Given this list of marker genes SLC25A21, UQCRFS1, RPL18AP16, MRPL44, OGDH, HSPA1L, MRPS30, FPGS, PDHA1, CPS1, ACOT9, ACAT1, GPT, CYBB, BID, CYC1, ALDH2, GDF15, HTATSF1, TIMM23, OAT, CYP11B2, MUTYH (NCBI Gene Id 4595), IDH3B, TSFM, FDX1, ACSL6, ABCB7, NDUFA5, COX11, FARS2, ABCF2, SLC25A14, TIMM13, PPIF, MTIF2, CYP27A1, GPX4, CYP11A1, WARS2, COX15, HSD3B1, FARSA, CLPX, ACADVL, GPD2, PDHX, COQ7, ACADM, GLUD1, NBN, NFS1 (NFS1 cysteine desulfurase), ABCB6, GOT2, UQCRC2, BCL2A1, NRF1, NDUFB5, MRPL16, MRPS16, BEX3, CYCS, NME4, TUFM, BCAT2, CYP27B1, CYB5B, FDXR, SLC1A3, MRPL12, ATP5MC3, GCAT, REXO2, TIMM8A, SHMT2, MLYCD, POLG2 (DNA polymerase gamma 2, accessory subunit), PPID, MRPL15, AZIN1, AGXT, HADH, HSPD1, SLC25A3, AKAP10, PDK4, MRPS14, DLAT, LYPLA2, MRPS15, CYP24A1, TIMM17A, SLC25A5, TXNRD2, MLH3, MRPL46, SDHB, BAD, IVNS1ABP, CASQ1, MRPL57, COX10, MTRF1, COX8A, HPS1, SCP2, COX6A2, TXN2, BCKDHB, PTPRA, HSD3B2, ACO2, PDK1, BLVRA (biliverdin reductase A), ACADSB, AKAP1, COX5A, PDP1, CRAT, IVD, MRPL35, MFN2, NDUFS1, SURF1, MPST, NDUFB3, NDUFA3, AIFM1, APAF1, TIMM10, CYB5R3, MRPS27, DGUOK, SLC25A28, H2BK1, TSPO (translocator protein), SLC25A37, FIBP, MRPL22, MRPS35, CLPP, MRPS18C, MRPL39, SUCLG1, GCK, OXCT1, CPT1B, MTCH1, TFAM, RPL3, RPS3A, NNT, AK4, DBT, CKMT1B, MRPS31, MRPL13, ATP5PF, PPOX, BDH1, VDAC2, GALR3, STAR, CYP11B1, GCFC2, DIABLO, MAST1, TK1, TBCB, UQCRB, MRPL42, ARG2, FH, MRPL19, ACSL4, BCL2, NDUFAB1, ACSL1, GOT1, SDS, IDH3G, GRID2, NPIPB3, AMT, GFM1, TK2, MRPL11, NR3C1, ATP7B, OTC, NDUFS2, ATP5PO, UQCRH, AFG3L2, NDUFC1, HMGCS2, ALDH18A1, PCK2, IDH3A, MRPL33, HAX1, NDUFS4, MTCH2, TOMM40, MRPS22, AMACR (NCBI Gene Id 23600), MMUT, SPG7, MRPL48, SDHA, GLYAT, CPOX, SLC25A40, ATP5F1B, TFB1M, ACAA2, COX7A1, ATP5MC1, NDUFA4, NDUFA2, NDUFS6, ATP5PB, ETFB, SLC1A1 (solute carrier family 1 member 1), NDUFB6, MRPL17, NPIPA1, IMMT, CASP8, SSBP1 (NCBI Gene Id 6742), ECHS1, MIPEP, MRPS17, CYBA (cytochrome b-245 alpha chain, NCBI Gene Id 1535), FXN, CPT2, NDUFS8, POLRMT, MCCC1, EMC8, BAK1, TOMM22, SHMT1, MRPL34, CA5B, HLCS, CS, CA5A, OPA1, ECI1, NDUFA7, ATP5F1D, PRDX3, GSR, MRPL18, FHP2, CYB5A, UQCRC1, SMCP, TST, GLS, ACSL3, HSPA9, TIMM8B, ATP5PD, STARD3, ATP5MC2, CLN3, MRPS18B, COX7B, ME2, LONP1, SLC25A4, POLG, NDUFS5, R3HCC1L, SUPV3L1, CRY1, ETFDH, NCAPH2, OXA1L, SDHC, UCP3, SLC25A15, MFN1, MRPS18A, MDH2 (malate dehydrogenase 2), NDUFA6, COX4I1, MTOR, HSPA1A, SUCLA2, ACADS, SLC9A6, BCS1L, DLST, ATP5MG, MRPL20, BCKDK, DAP3, MBD3, COX6A1, MRPS28, MTHFD1, MRPS34, NDUFC2, TAT, MAOA, ATP5F1E, MRPS2, ABAT, BCKDHA, SARDH, TIMM44, CNOT7, CPT1A, PIN4, SBNO2, IDH2, SOD2, ACSL5, MRPL9 (mitochondrial ribosomal protein L9), HK1, GATM (NCBI Gene Id 65211), PCCB, OGG1, HSPE1, NDUFV2, LARS2, DHODH, BNIP3, NDUFB2, DECR1, VDAC3, ATP5ME (ATP synthase membrane subunit e), CKMT2, HMGCL, MAOB, ABCB8, COX7A2, NDUFB4, COX7C, NDUFB1, PDHB, SLF2, MRPS12, ATP5F1C, OAZ3, ATP5IF1, ALDH4A1, NDUFA1, COX17, UROS, COX5B, PMPCB, SLC25A11 (NCBI Gene Id 8402), FECH, MRPL2, GLS2, MRPS7, ACAD8, NDUFA9, TOMM34, TIMM17B, MRPL4, ALAS1, HADHB, RAF1, ACP6, SDHD, HCCS, SLC25A13, SLC25A10, TRAP1, MTHFD2, TOMM20, DNASE2, ATP5MF, TXN, BCL2L11, ZNF33B, UQCR11, AK2, NDUFS3, TIMM9, ODC1, SLC25A20, ME3, MRPS33, ACADL, CDC37P1, NDUFB8, GAL3ST1, MPO, BNIP3L, DUT, PC (pyruvate carboxylase), HADHA, DLD, NDUFS7 (NCBI Gene Id 4727), BAX, GATB, RPLP2, SLC25A17, GCDH, COX6C, SLC25A1, COX7A2L, PDK3, MRPL24, LMF2, ENDOG, MRPS11, TOMM70 (NCBI Gene Id 9868), MRPS10, DNM1L, COX6B1 (NCBI Gene Id 1340), ETFA, DMAC2L, NDUFA8, PCCA, UCP1, MRPL49, TIMM22, BCL2L1, SLC25A12, NDUFB7, CBARP, UCP2, PYCR1, HCLS1, NDUFA10, here is a description of the gene set: from publication Mootha VK, Lindgren CM, Eriksson KF, Subramanian A, Sihag S, Lehar J, Puigserver P, Carlsson E, Ridderstråle M, Laurila E, Houstis N, Daly MJ, Patterson N, Mesirov JP, Golub TR, Tamayo P, Spiegelman B, Lander ES, Hirschhorn JN, Altshuler D, Groop LC (PMID 12808457) Human Gene Set: MOOTHA_HUMAN_MITODB_6_2002 DNA microarrays can be used to identify gene expression changes characteristic of human disease. This is challenging, however, when relevant differences are subtle at the level of individual genes. We introduce an analytical strategy, Gene Set Enrichment Analysis, designed to detect modest but coordinate changes in the expression of groups of functionally related genes. Using this approach, we identify a set of genes involved in oxidative phosphorylation whose expression is coordinately decreased in human diabetic muscle. Expression of these genes is high at sites of insulin-mediated glucose disposal, activated by PGC-1alpha and correlated with total-body aerobic capacity. Our results associate this gene set with clinically important variation in human metabolism and illustrate the value of pathway relationships in the analysis of genomic profiling experiments. Mitochondrial genes; based on literature and sequence annotation resources and converted to Affymetrix HG-U133A probe sets. studied in species Homo sapiens